The following is a description of a gene set: Genes having at least one occurrence of the motif NNTGTYCT in the regions spanning 4 kb centered on their transcription starting sites. This matches the NR3C1 transcription factor binding site V$GR_Q6_01 (v7.4 TRANSFAC). species: Homo sapiens Human Gene Set: GR_Q6_01, and this is the list of marker genes: ARL4C, CCDC140, PXN, SNX17, LCOR, UBE2K, CDH2, CCM2L, TNMD, DOK1, PMCHL1, GRP, AKAP5, WNT8B, HOXB7, DNAAF6, ETS1, IKZF4, KHDRBS1, PROK2, TIMD4, PAX2, SLC2A2 (NCBI Gene Id 6514), CSNK1G1, GPANK1, SLC35D1, PLSCR3, MRPS18B (mitochondrial ribosomal protein S18B), EPB41L3, DND1, TBL1XR1, SMAD6, CUEDC1, DLX2, RESF1, CDKN1B, CHAT, RAB3GAP2, RBM4B, MARCHF7, CXCR4, FEN1, LINC02880, MPZ, CPNE1, BNIP2, ZNF24, OTX1, ZNF436, FAM117A, GREB1, ELAVL4, LRRC37BP1, KCTD15, LGI1, PRKCG, SLC38A2, PPP2R3A, NCOA3, PACSIN3, MAGEC3, FANK1 (fibronectin type III and ankyrin repeat domains 1), NCKAP5, ELF5, PDGFB, TEAD2, SCNN1A, QRICH1, DLX3, NUP62CL (NCBI Gene Id 54830), LUC7L3, MASP1, BACH1, LTBP3, MARCKSL1, FRA10AC1, EP300, DCUN1D3, EDARADD, EIF2B4, PAX3, TECTA, LEAP2, GASK1B, KANSL1, MAGED1, CIART, ADGRG6, TCN2, MBNL2, KCNK10, C6orf62, NSD3, AQP4-AS1, ZBTB45, SIX1, WT1-AS, SLC7A11, ZNF423, SLC18A3, CREBBP, AQP4, MBOAT2, NPEPPS, RCN1, DLG2, ST13, PPP1R10, EPHA7 (EPH receptor A7), ZNF516-DT, IL1RAPL1 (NCBI Gene Id 4399), CTNND2, TXNL4B, CAMLG, ADISSP, HOXB5, CPA3, TGIF1, RNF13 (ring finger protein 13), SYNCRIP, NDUFAF4, BCL7A, EFNA1, NEUROD6, NUDT16, SSH2, ZC3H11A, SMC6, TUBB2B (NCBI Gene Id 347733), ARG2, ABCG8, MMP14, DPF3, LBX1, MTMR10, HOXC4, CCDC6 (NCBI Gene Id 8030), MRM1, ME1, ETV6, RORA, NDST2, SGMS2, WFIKKN2, ZNF436-AS1, PCDH8, RREB1, HOXA2, TRIP11, NSD2, NUDT16L2P, SLC25A10, PDYN, LRMDA, QKI, AMOTL1, SF3B4 (splicing factor 3b subunit 4), APBA1, MAP1B, XPNPEP3, WNT4, PSEN1, RBX1, DHX40, PARP8, ATP8A1, RTKN, WWP2, SESTD1, PCDH1, NEDD8, NIPBL, PHF3, NCDN, FEM1C, SRGN, LASP1, NHLH1, RUNX1T1 (NCBI Gene Id 862), TERF2, JMJD1C, R3HDM2, ZNF654, RND1, TUBB4A, ZNF532, ELAVL2, EHF (ETS homologous factor), KMT2D, PRDM1, SEMA4C, LINGO1, OLFML2A, LINC00472, HOXC5, HOXB3, CASZ1, DHX38, LOXL3, NLK, RNF152, ADGRD1 (adhesion G protein-coupled receptor D1), SMG9, FGD4, DHX29, PCBP4, EYA2, CHST9, TMEM258, NRP2, BRS3, C2CD2L, EIF4G2, PDCL2, CALD1, AKAP7, RSRC1, PMCHL2, CER1 (cerberus 1, DAN family BMP antagonist), SYT6, GEN1, LOX (lysyl oxidase), PPM1B, PDAP1, CDC42EP4, TSPAN8, WDR49, ZP3, GOLGA2P11, STMN1, F11, EMILIN1, BRME1, OTX2, B3GNT5, FOXA1, TET2, PDZD2, ATRNL1, MYH4, KRT23, ENOX2, GIPC2, GCNT3, KLF3, TYRO3, TPM1, PCDH9, MYCBP, ZIC4, ELOVL4, C22orf31, SV2B, TNNT3, CYB5R4, AFF3, GMPR2, KLF3-AS1, C19orf48P, MTREX, SDC1, PHF21A, PRRG4, ANK3, KLHL5, DYNLL1, BHLHA15, LYRM1, SEC24D, ITPR3, SULT2A1, ARPP21, GPM6A, OPN1SW, UBL4A, NOG, LRRTM3, SESN3, MMP11, AKNAD1, SCHIP1